The following is a description of a gene set: Mouse Gene Set: GOMF_PHEROMONE_BINDING studied in species Mus musculus Binding to a pheromone, a substance, or characteristic mixture of substances, that is secreted and released by an organism and detected by a second organism of the same or a closely related species, in which it causes a specific reaction, such as a definite behavioral reaction or a developmental process., and this is the list of marker genes: Vmn1r218, Vmn1r193, Vmn1r35, Vmn1r18, Vmn1r197, Vmn1r227 (vomeronasal 1 receptor 227), Vmn1r199, Mup17, Vmn1r7, Vmn1r75, Vmn1r205, Vmn1r196, Vmn1r234, Vmn1r82, Vmn1r22, Lcn3, Vmn1r83, Vmn1r87, Vmn1r24, Vmn1r74, Vmn1r226, Vmn1r70, Vmn1r200, Vmn1r23, Vmn1r38, Vmn1r208, Mup4, Vmn1r30, Vmn1r237, Vmn1r229, Mup1, Vmn1r219, Vmn1r220, Vmn1r19, Vmn1r214, Vmn1r185, Mup11, Vmn1r210, Vmn1r190-ps, Vmn1r222, Vmn1r189, Vmn1r235, Vmn1r4, Vmn1r217, Vmn1r198, Vmn1r27, Vmn1r195, Vmn1r73, Vmn1r203, Mup3, Vmn1r67, Vmn1r231, V1rg10, Vmn1r213, Vmn1r9, Vmn1r202, Vmn1r215, Vmn1r192, Vmn1r232, Vmn1r80, Vmn1r26, Vmn1r6, Mup5, Vmn1r201, Vmn1r21, Vmn1r81, Vmn1r188, Vmn1r78, Vmn1r216, Vmn1r228, Vmn1r230, Mup20, Vmn1r191, Vmn1r236, Mup18, Vmn1r36, Vmn1r32, Vmn1r233, Vmn1r212, Vmn1r206, Vmn1r28, Vmn1r84, Vmn1r76, Vmn1r5, Vmn1r16, Vmn1r8, Vmn1r225, Vmn1r17, Vmn1r211, Vmn1r89, Mup2, Lcn4, Vmn1r37, Vmn1r33, Vmn1r66